Given this list of marker genes ERN1, CCR6, LPAR1, KRT76, CLBA1, HLA-J, PALM, NCF1C, DLX6, FAP, PARVB, ASIP (NCBI Gene Id 434), ADGRL4, RNF167, PPIB, ARFGAP3, SNX22, G6PD, IFI30, TPPP2, TMEM190, ITPR3, TEAD2, ADAMTS20, RNPEP, SFTPC, PTPN11, SURF4 (NCBI Gene Id 6836), ZNF574, KLRB1, DUXAP10, RBP5, RORC, FOXRED2, PTAFR, CCDC89, ATXN7L3, MMP9, ALDOAP2, GRIN2B, UBTD1, TSPAN9, FMNL1, SH3BP1, MTTP, CYFIP1, ST20 (NCBI Gene Id 400410), GLI3, LINC01165, DDAH2, CACNB3, STARD8, MUC4, KIT, FENDRR, NPM2, SLC15A4, MATN2, VEPH1, SAMD4B, PACSIN3, CAPN2, LINC01343, CYTH3, CLPTM1, CLEC12A, FAAP20, LINGO1, SLC4A10, SLC45A4, AGBL1, ZNF99 (zinc finger protein 99), PLXND1, SOX17, AGTR2, AOPEP, PRKCSH, LINC02981, ENPP1, DNM3OS, ABHD15, UCMA, NXPH4, RPN1, MUC5AC, BAALC-AS2, DDOST, MYDGF, SCG5, IGF2-AS (NCBI Gene Id 51214), COL19A1, MBOAT7, SLC45A3, ANK1, LINC01106, TPSD1, RC3H1, LRP2, XPNPEP2, NCR3, TLN1 (talin 1), LY6H, CRIM1, EPB41L4B, SCN1B, PKNOX2, CORO1C, LINC01845, SERPINA10 (serpin family A member 10), CYP4F29P, SIX5, ASB10, AKAP8L, KIF1B, SCNN1A, P4HB, ELL, RGS11, IL23R, DSCAML1, FAM181B, IFNGR1, OVOL3, RRBP1, FAM43A, LIMS1, GRN, MBD3L1, KCTD5, HRH4, GALNT9 (NCBI Gene Id 729185), SCART1, PLXNB2, ALMS1P1, SLC15A1, DGCR5, PPAN, PRKD1, PRKACG, DLG5, NCS1, SLAMF1, DENND3, ARF6, TUSC2, PTPRE, CXCL11, CLDN11, LINC00421, LINC01936, DAB2IP, PRR19, ASZ1, LINC02481, SLC38A10, CDH2, FURIN, ZRSR2P1, WTIP, NYX, GABRE, TIMM8A, MVD, DKK2, ELF4, CRB3, COL4A6 (NCBI Gene Id 1288), CD40LG, LILRA4, N4BP3, RNF115, ENSG00000290598, PRSS47P, ARF1, MUC3A, SCN7A, TMEM230, MAF1, LATS2, CDH19, ELF5, KMT2D, ZZEF1, CDC42EP3, TTLL4, ZNF474, HCG4B, CCDC144NL-AS1, RDUR, LIMK1, SLC16A3, WDR1, E2F1, HFE, LINC01134, RPS6KB2, here is a description of the gene set: Genes up-regulated in monocytes (24h): untreated versus M. tuberculosis 19 kDa lipopeptide. from publication Schenk M, Krutzik SR, Sieling PA, Lee DJ, Teles RM, Ochoa MT, Komisopoulou E, Sarno EN, Rea TH, Graeber TG, Kim S, Cheng G, Modlin RL (PMID 22447076) studied in species Homo sapiens human blood monocytes were isolated, activated and harvested at several timepoints In this study, we identified genes that were differentially expressed in human monocytes activated with eiter NOD2L and/or TLR2/1L. Human Gene Set: GSE34156_UNTREATED_VS_24H_TLR1_TLR2_LIGAND_TREATED_MONOCYTE_UP